Given this list of marker genes Esr1, Hspa1b, Hspa1a, Hsf1, Akt1 (NCBI Gene Id 268604), Foxo3, Dnaja1, Sirt3, here is a description of the gene set: Mouse Gene Set: REACTOME_MITOCHONDRIAL_UNFOLDED_PROTEIN_RESPONSE_UPRMT Mitochondrial unfolded protein response (UPRmt) studied in species Mus musculus